Given this list of marker genes Cenph, Mcm6, Fzd3, Sox7, Mcm5, H2-K1, Lrig1, Snx5, Il1rl1, Art2b, Has2, Rab3c, Vav1, Sptbn4, H2-D1, Prps1, B3gat3, Dkk3, Mxd3, Cdt1, Ednra, Socs4, Adam26a (ADAM metallopeptidase domain 26A), Idh1, Otc, Rbbp4, Nr1h4, Apoc1, Mcm7, Hoxd3, Slc22a18, Ccl7, Hmgb1 (high mobility group box 1), Slc4a4, Vmn1r51, Lyz2, Stmn1, Mup3, Rad18, Hmmr, Tk1, Chtf18, Ung, Grem1, Ptgs1, Creb1, Ighm, D17H6S56E-5, Defb5, Apcdd1, Hspb7, Aspm, Ccnb2, Myo1b, Pcolce2, Mtnr1a, Fgf7, Ldlr, Hmgb3, Nipsnap1, Spp1, Pcdhb19, Ucp3, Pola1, Elovl6, Jmjd6, Dut, Chst2, Uhrf1, Fars2, Rab27a, Rest, Lgr5, Cenpf, Slc35c2, Sfxn1, Cyp51, Lig1, Birc5, Thy1, Fn3k, Lig3, Lpar1, Alox8, Folh1, Top2a, Itga4, Fdft1, Nkx2-3, Tmem45a, Slc29a1, Ccl2, Ly6c1, Polh, Setd1a, Tspan8, Gfra1, Foxm1, Aurka, Gatb, Fmod, Klra4, Clcn1, Ifi205, Prdx4, Chrdl1, Thbs4, Prkg2, Msh2, Col6a3, Cxcl5, Fads2, Mad2l1, Gnb4 (guanine nucleotide binding protein (G protein), beta 4), Dusp9, Col15a1 (NCBI Gene Id 12819), Ptgds, Matn2, Stard4, Eef1a1, Fcgr2b, Fbxw14, Mmp13, Dnajc2, Tfap4, Mycbpap, Gk2, Mki67, Exo1, Mchr1, Dlx3, Suv39h2, Hmgcs1, Ptpn2, Ifi202b, Neurl1a, Ttk, Mtch2, Kif11, Terf1, Haspin, Diaph3, Spag5, Thbs2, Tac1, Tdrd1, Ptpro, Khdrbs1, Gzmd, Nsdhl, Tgfbi, Ttf1, Igfbp5 (NCBI Gene Id 98676), Ank, Spa17, Scd2, Mcm3, Nlrp4c, Mthfd2, Mrpl19, Api5, Ccn5, Crip1, Lin7b, H3c7, Tnfsf11, Pcdha10, Gjb3, Sftpc, Aurkb, Ift80, Tfb1m, Msmo1, Hmgb2, Fdps, Gpr84, Smc2, Tcp1, Pdgfra, Ripk4, Plscr2, Bcat1, Plcb1, Lum, Gjd2os, Ly6a, Elavl3, Cdc6 (cell division cycle 6), Pfdn5, Cdc25c, Racgap1, Bub1, Rad51ap1, Tacc3 (transforming, acidic coiled-coil containing protein 3), Ccna2 (cyclin A2), Ncapg, Per3, Crabp1, Scarb1, Plk1, Cyct, Fus, Shcbp1, Dkk2, Lmnb1, Uts2r, Gzma, Gpr65, Ceacam14, Cts6, Prss29, Serpina1a, Sqle, Il1rapl2, Tgfbr1, Nasp, Semg1 (NCBI Gene Id 99448), Kif22, Aldh18a1, Nectin4, Mcm4, Il1r1, Cenpa, Tnfrsf1b, Nt5c1b, Cyp7b1, Fabp9, Fen1, Prelp, Mrpl52, Bub1b, Tnni3, Nsg1, Steap4, Zfp143, Piga, Msh3, Dhcr24, Cenpe, Clec3b, Vmn2r88, Idi1, Abhd3, Kif20a, Sod3, Steap1, Anp32e, Cyp2c50, Ccnb1, Kif2c, Cdca3, Pla2g1b, Cyp3a11, Rps6ka4, Lhx4, Plk4, Atp6v1e1 (NCBI Gene Id 76771), Uty, Axin2, Tubb2a, Slc4a10, Trib3 (tribbles pseudokinase 3), Galr1, Tnfrsf22, Prc1, Lep, Hells, Rfc4, Trip13, Avpr1a, Slc25a5, Kif23, Pof1b, Slc25a26, Ms4a4d, Prl3d1, here is a description of the gene set: Mouse Gene Set: AFFAR_YY1_TARGETS_DN studied in species Mus musculus Constitutive ablation of the Yin Yang 1 (YY1) transcription factor in mice results in peri-implantation lethality. In this study, we used homologous recombination to generate knockout mice carrying yy1 alleles expressing various amounts of YY1. Phenotypic analysis of yy1 mutant embryos expressing approximately 75%, approximately 50%, and approximately 25% of the normal complement of YY1 identified a dosage-dependent requirement for YY1 during late embryogenesis. Indeed, reduction of YY1 levels impairs embryonic growth and viability in a dose-dependent manner. Analysis of the corresponding mouse embryonic fibroblast cells also revealed a tight correlation between YY1 dosage and cell proliferation, with a complete ablation of YY1 inducing cytokinesis failure and cell cycle arrest. Consistently, RNA interference-mediated inhibition of YY1 in HeLa cells prevents cytokinesis, causes proliferative arrest, and increases cellular sensitivity to various apoptotic agents. Genome-wide expression profiling identified a plethora of YY1 target genes that have been implicated in cell growth, proliferation, cytokinesis, apoptosis, development, and differentiation, suggesting that YY1 coordinates multiple essential biological processes through a complex transcriptional network. These data not only shed new light on the molecular basis for YY1 developmental roles and cellular functions, but also provide insight into the general mechanisms controlling eukaryotic cell proliferation, apoptosis, and differentiation. from publication Affar el B, Gay F, Shi Y, Liu H, Huarte M, Wu S, Collins T, Li E, Shi Y (PMID 16611997) Genes down-regulated in MEF cells (embryonic fibroblast) expressing ~25% of YY1.